The following is a description of a gene set: Human Gene Set: IKEDA_MIR1_TARGETS_UP Genes up-regulated in hypertrophic hearts (due to expression of constitutively active form of PPP3CA) and predicted to be targets of miR-1 microRNA. from publication Ikeda S, He A, Kong SW, Lu J, Bejar R, Bodyak N, Lee KH, Ma Q, Kang PM, Golub TR, Pu WT (PMID 19188439) Calcium signaling is a central regulator of cardiomyocyte growth and function. Calmodulin is a critical mediator of calcium signals. Because the amount of calmodulin within cardiomyocytes is limiting, the precise control of calmodulin expression is important for the regulation of calcium signaling. In this study, we show for the first time that calmodulin levels are regulated posttranscriptionally in heart failure. The cardiomyocyte-restricted microRNA miR-1 inhibited the translation of calmodulin-encoding mRNAs via highly conserved target sites within their 3' untranslated regions. In keeping with its effect on calmodulin expression, miR-1 downregulated calcium-calmodulin signaling through calcineurin to NFAT. miR-1 also negatively regulated the expression of Mef2a and Gata4, key transcription factors that mediate calcium-dependent changes in gene expression. Consistent with the downregulation of these hypertrophy-associated genes, miR-1 attenuated cardiomyocyte hypertrophy in cultured neonatal rat cardiomyocytes and in the intact adult heart. Our data indicate that miR-1 regulates cardiomyocyte growth responses by negatively regulating the calcium signaling components calmodulin, Mef2a, and Gata4. studied in species Mus musculus, and this is the list of marker genes: CLTC (NCBI Gene Id 9511), SYNCRIP, PRKACB, CITED2, CPEB1, KAT6B, E2F5, PDCD10, GPRC5B, SPRED1, BDNF, SF3B1, FNDC3B, ZFP36L2, YWHAQ, PMP22 (NCBI Gene Id 5376), RRBP1, CRIM1, ARFIP1, DDX3X, HNRNPR, TPM3, RSBN1, YWHAZ, GCLC, CNN3, ARCN1, UBE2H, FZD7, TBC1D15, ACVR1, NCL, IGF1, ARHGAP21, EDN1, PLK2, FNDC3A, SEC62, CORO1C, GNPDA2, EFNB2, ARF4, ANP32E, JAG1, SEC63, NFAT5, PICALM, SMAP1, CREM, ATP6V1A, ARRDC3, PDCD4, HNRNPK, VAMP4